Given this list of marker genes Adal, Nt5c2, here is a description of the gene set: studied in species Mus musculus part of: Abacavir ADME Reactome Pathway: Abacavir metabolism This event has been computationally inferred from an event that has been demonstrated in another species.<p>The inference is based on the homology mapping from PANTHER. Briefly, reactions for which all involved PhysicalEntities (in input, output and catalyst) have a mapped orthologue/paralogue (for complexes at least 75% of components must have a mapping) are inferred to the other species. electronically inferred by orthology from the curated human pathway